Given this list of marker genes CDKN1B, COL1A1, COL5A1, CXCR4, GATA2, SRY, PLG, COL5A2, AR, MAD1L1, STK11, FGFR3, COL3A1, here is a description of the gene set: studied in species Homo sapiens Human Gene Set: HP_ABNORMAL_UTERINE_CERVIX_MORPHOLOGY An anomaly of the neck of the uterus (lower part of the uterus), called the uterine cervix. Abnormal uterine cervix morphology